The following is a description of a gene set: studied in species Mus musculus Mouse Gene Set: GOBP_ADENOSINE_TO_INOSINE_EDITING The conversion of an adenosine residue to inosine in an RNA molecule by deamination., and this is the list of marker genes: Adarb2, Adat2, Adad2, Adad1, Adarb1, Adar